Given this list of marker genes Pigu, Pemt, Elovl5, St6galnac6, Alox12b, Cers2, Pigk, Sphk2, Tlcd3b, Smpd2, Abca8b, Gpaa1, St3gal6, Sccpdh, Degs2, Fut9, Ormdl1, Acer3 (NCBI Gene Id 71401), Asah2, St3gal2, Sgms1, St8sia2, Pigp, Pgap3, Pigm, Cers5, A4galt, Atg7, B4galt4, B4galt5, Kdsr, Gal3st2, Agk, Aloxe3, Mppe1, Pla2g6, Pigl, P2rx7, Pigv, St3gal4, Fut4, St3gal1, Pigg, B3gnt5, Ugt8a, Elovl3, Mecr, Smpd4, Elovl7, 6430550D23Rik, Dpm2, Smpd1, Sgms2, Pigo, Pgap4, Sptlc1, Cers3, Ccn1, Pigx, Elovl2, Ormdl3, Piga, Smpd5, Hacd1, Cyp4f39, St6galnac1, St6galnac4, Pigh, St8sia4, St8sia5, Ormdl2, Pigw, B3galt4, Dpm3, Pgap1, B4galnt1, Hacd4 (3-hydroxyacyl-CoA dehydratase 4), Cers4, St8sia3, Pyurf, B3galt2, Paqr4, Ugcg, Pigs, Degs1, Abca2, Pigt (NCBI Gene Id 78928), Prf1, Cers1, St6galnac3, Gzmb, Cwh43, St8sia6, Degs1l, P2rx1, Sptlc3, Hacd3, Abca8a, Gba1, Pnpla1, Pigf, A3galt2, Pigq, Sptssb, Pgap2, Gal3st3, Gal3st1, Sptlc2, Tm9sf2, Casp1, Sphk1, Smpd3, Elovl4, B4galt3 (NCBI Gene Id 98672), Pigc, Pigyl, Gsdmd, Cerkl, Prkcd, Zfp750, Elovl1, Gm6993, Enpp7, Hacd2, Pign, Sptssa, Acer1, St3gal3, Vapa, Samd8, B3galt1, Cers6, Sirt3, Pigz (phosphatidylinositol glycan anchor biosynthesis, class Z), Osbp, St6galnac5, B4galt6, Acer2, Pigb, Fa2h, Asah1, Slc30a5, Casp7, Elovl6, Dpm1, here is a description of the gene set: studied in species Mus musculus The chemical reactions and pathways resulting in the formation of membrane lipids, any lipid found in or associated with a biological membrane. Mouse Gene Set: GOBP_MEMBRANE_LIPID_BIOSYNTHETIC_PROCESS